Given this list of marker genes ORC4, ITIH3, TBPL1, TMEM258, GTF2B, BTK, PIP5K1A, TMEM59, DNM1L, UNC50, TMEM98, LIN9, CHRAC1, RAB5A (RAB5A, member RAS oncogene family), DSCAML1, MUC13, BCKDHA (branched chain keto acid dehydrogenase E1 subunit alpha), TTYH2, NPL, ZNF207, ZBTB33 (NCBI Gene Id 10009), TLX3, DAPP1, UTRN, RDH11, EMSY, SLCO5A1, BIRC2, KPNA4, TMEM183A, ARAF, ZFYVE16, KCMF1, SCYL1, FOXJ2, TNFSF14, STAMBPL1, DMTN, TP53INP1, STMN1, SLC6A8, PLAU, ZIM3, VSTM2B, SIX1, MAP3K8, MTMR1, KIN, NATD1, GCH1, TEF, ETNK1, MXRA8, REX1BD, CDC42EP3, UBE2B, GAL3ST1, FHL1, PABPN1, IL6, CLCF1, CRTAC1 (NCBI Gene Id 55118), RHBDD3, NDE1, RPS21, APBB3, REST, CDK2, MTCP1, MDM2, LZTFL1, TSC22D1, TXLNG, EIF1, CEBPD, PRELP, SAP30BP, POLR2J (NCBI Gene Id 5439), RABGAP1, ATG4D, RETN, TEX101, PTGR1, TTC39C, PGRMC1, FKBPL, KIF3C, TNFAIP2, IL18RAP, LTC4S, TRPM5, DEPDC7, RPE65, ELF1, FUCA1, SLC22A13, UPB1, SGMS1, MT1E, PSMA1, PRODH, IL12B, TTK, RAB13, MKI67, CAP1, SH3GL1, CBX4, ATP5F1E, SLAMF7, MTHFD2, RITA1, MPO, ADSS2, PPP2R2A, FAS (Fas cell surface death receptor), ZNF410, PTPRG, MAP3K1, PRDM1, UAP1, AKR1A1, TMEM39A, RASA2, BTBD10, IER5, KPNA3, CHAC2, SPARC, KCNMB2, GOLM1, TSC22D3, FHIP1B, TSPAN17, SDF2, SLC15A2, DOK1, SPSB1, PTGS2, PHLDB1, NRAP, RSRP1, SFI1, ATRN, EXTL1, IDO2, RREB1, ABRACL, RBM47 (RNA binding motif protein 47), PRCP (prolylcarboxypeptidase), NPRL2, TMBIM1, PSMC1, ATXN2, NTSR2, SLC30A1, CLP1, CSNK1A1, OTOS, SAMSN1, RAB2B, DNAJB2, ZC3H3, ZDHHC4, FGF12, ARIH1, DNASE1L2, NEAT1, RACGAP1, SERPINB2, PLSCR1, DDIT4, BTG4, CSNK1E, OST4, SPO11 (SPO11 initiator of meiotic double strand breaks), TRIB3, B2M, TBC1D15, FAM234B, RIPK4, DUT, SFPQ, ANKRD33B, NFKBIZ, HS6ST3, HADH (NCBI Gene Id 3033), CCDC90B, TNFRSF11A, MRNIP, ZBTB1, RND3, BTG1, STRN4, ABCB10, GLRA3, TMEM134, SLURP1, SELP, here is a description of the gene set: Genes down-regulated in comparison of dendritic cells (DC) stimulated with Pam3Csk4 (TLR1/2 agonist) at 1 h versus DC cells stimulated with CpG DNA (TLR9 agonist) at 1 h. mouse primary BMDCs were stimulated with tlr ligands and gene expression changes were profiled on Affymetrix arrays from publication Amit I, Garber M, Chevrier N, Leite AP, Donner Y, Eisenhaure T, Guttman M, Grenier JK, Li W, Zuk O, Schubert LA, Birditt B, Shay T, Goren A, Zhang X, Smith Z, Deering R, McDonald RC, Cabili M, Bernstein BE, Rinn JL, Meissner A, Root DE, Hacohen N, Regev A (PMID 19729616) Human Gene Set: GSE17721_PAM3CSK4_VS_CPG_1H_BMDC_DN studied in species Homo sapiens